The following is a description of a gene set: LRR FLII-interacting protein 1 (LRRFIP1) activates type I IFN production species: Homo sapiens Human Gene Set: REACTOME_LRR_FLII_INTERACTING_PROTEIN_1_LRRFIP1_ACTIVATES_TYPE_I_IFN_PRODUCTION, and this is the list of marker genes: IRF3, CREBBP, LRRFIP1, EP300, CTNNB1